Given this list of marker genes GDPD5, GDE1, ENPP6, GDPD3, GDPD1, PNPLA6, PNPLA7, here is a description of the gene set: Human Gene Set: REACTOME_GLYCEROPHOSPHOLIPID_CATABOLISM species: Homo sapiens Glycerophospholipid catabolism